The following is a description of a gene set: Human Gene Set: GOBP_TRANSCRIPTION_INITIATION_AT_RNA_POLYMERASE_III_PROMOTER A transcription initiation process that takes place at a RNA polymerase III gene promoter. Transfer RNAs (tRNA) genes, as well as some other non-coding RNAs, are transcribed by RNA polymerase III. studied in species Homo sapiens, and this is the list of marker genes: POLR3H, GTF3C5, GTF3C4, GTF3C1, BRF1, SNAPC5, CRCP, BDP1